Given this list of marker genes Taf7, Tuft1, Polr2e, Eny2, Polr3d, Pola1, Gtf2e1, Gtf2f1, Taf3, Rtf1, Polr1a, Polr1g, Polr1c, Taf4b, Pola2, Polr3g, Gtf2h4, Polr2f (polymerase (RNA) II (DNA directed) polypeptide F), Polr3h, Taf5, Taf6, Taf7l, Gtf2h2, Polr2l (NCBI Gene Id 66491), Tert, Taf11, Usp22, Paf1, Gtf2a1, Polr1h, Prim1, Polr2h, Polrmt, Tbpl1, Gtf2a1l, Crcp, Taf1, Cdk7, Atxn7, Polr1b, Taf9b (NCBI Gene Id 407786), Polr1f, Polr3b, Taf8, Taf5l, Polr2k, Polr2c, Tcea1, Tbp, Trrap, Mnat1, Taf6l, Tada3, Pex2, Gtf2b, Polr2j, Taf12, Skic8, Atxn7l3, Myzap, Polr3gl, Polr3c, Taf13, Polr3k, Polr3a, Znfx1, Gtf2h5, Primpol (NCBI Gene Id 408022), Taf10, Polr2g, Polr3f, Polr2m, Ccnh, Kat2a, Polr2d, Ercc2 (excision repair cross-complementing rodent repair deficiency, complementation group 2), Gtf2f2, Gtf2e2, Polr1d, Ercc3, Prim2, Supt3, Polr1e, Gtf2a2, Taf2, Taf9, Polr2a, Gtf2h3, Cdc73, Gtf2h1, Rpap1, Psmc5, Polr2b, Leo1, Taf4, Ctr9, Polr2i, Polr3e, here is a description of the gene set: Any complex that possesses RNA polymerase activity; generally comprises a catalytic subunit and one or more additional subunits. species: Mus musculus Mouse Gene Set: GOCC_RNA_POLYMERASE_COMPLEX